The following is a description of a gene set: Human Gene Set: HP_ABNORMAL_FACTOR_VIII_ACTIVITY species: Homo sapiens A deviation from the normal activity of coagulation factor VIII. Factor VIII (fVIII) is a cofactor in the intrinsic clotting cascade that is activated to fVIIIa in the presence of minute quantities of thrombin. fVIIIa acts as a receptor, for factors IXa and X. Abnormal factor VIII activity, and this is the list of marker genes: THBS2, LMAN1, F8, VWF, MCFD2, SOS1 (SOS Ras/Rac guanine nucleotide exchange factor 1)